The following is a description of a gene set: species: Homo sapiens Paroxysmal dyskinesia Episodic bouts of involuntary movements with dystonic, choreic, ballistic movements, or a combination thereof. There is no loss of consciousness during the attacks. Human Gene Set: HP_PAROXYSMAL_DYSKINESIA, and this is the list of marker genes: GRIN1, SLC2A1 (solute carrier family 2 member 1), KCNMA1, ADCY5, SCN8A, ATP1A2, SLC32A1, PDE2A, ATP1A3, CACNA1A (calcium voltage-gated channel subunit alpha1 A), MECR, SPTAN1, PNKD, SH2B1, PRRT2, SLC1A3